Given this list of marker genes Trdmt1, Nsun4 (NCBI Gene Id 72181), Nsun3, Mettl6, Mettl8, Nsun6, Mettl2, Ftsj1, Nsun2, here is a description of the gene set: Mouse Gene Set: GOMF_TRNA_CYTIDINE_METHYLTRANSFERASE_ACTIVITY Catalysis of the reaction: S-adenosyl-L-methionine + tRNA = S-adenosyl-L-homocysteine + tRNA containing methylcytosine. species: Mus musculus